Given this list of marker genes CAMSAP2, OGN, AASDHPPT, NPY5R, SLITRK3, GSPT2, CDYL, TRIM2, SGCB, SLITRK5, HSPE1, GLT8D2, TCFL5, SLC40A1, RPL22L1, CASK, TARS1, PHIP, SBF2, DMP1, LOX, DMC1, C18orf54, CCDC50, BAHCC1, SLC17A3, BAG2, BLMH, GINS1, HSDL2, AIMP1, OLIG3, SPIN2A, NCEH1, SLAMF6, GPATCH8, FRYL (NCBI Gene Id 728298), REEP3, SPIN2B, TWIST1, SLMAP, OTULINL, ASPH, FKBP5, here is a description of the gene set: Human Gene Set: MIR101_5P studied in species Homo sapiens from publication Chen Y, Wang X (PMID 31504780) Genes predicted to be targets of miRBase v22 microRNA hsa-miR-101-5p in miRDB v6.0 with MirTarget v4 prediction scores > 80 (high confidence targets).